Given this list of marker genes PFKP, PDLIM4, GYS1, ENO2, ALDOC, F3, VEGFA, ANGPTL4, PLIN2, BACH1, SLC2A1, JUN, BNIP3L, TPI1, ALDOA, AMPD3, LDHA, here is a description of the gene set: studied in species Homo sapiens Genes up-regulated in normal fibroblasts under hypoxia conditions. from publication Kim H, Lee DK, Choi JW, Kim JS, Park SC, Youn HD (PMID 14499499) Human Gene Set: KIM_HYPOXIA Little is known about the detail of hypoxia-responsive gene expression patterns in advanced age, even though aging is thought to be partially associated with a decreased response to hypoxia. In the present study, we identified several hypoxia-inducible genes and investigated the effect of aging on hypoxic gene expression profiles using cDNA microarray analysis of young/old human diploid fibroblasts. Of genes in the microarray, we found that genes involved in angiogenesis, defense against oxidative stress, and transcription regulation are severely impaired in senescent cell, which is consistent with the fact that aged cells have attenuated responses to various stimuli.